The following is a description of a gene set: Genes having at least one occurrence of the motif TGACCTTTGNCCY in the regions spanning 4 kb centered on their transcription starting sites. This matches the PPARA transcription factor binding site V$PPAR_DR1_Q2 (v7.4 TRANSFAC). species: Homo sapiens Human Gene Set: PPAR_DR1_Q2, and this is the list of marker genes: INSR, PHYHIP, DCTN1, PRDM16, SPACA6, CNOT9, ARL6IP1, ARHGEF7, TMEFF1, IGF2BP1, AQP7, PDZK1, COL16A1, HHEX, IFFO1, TP53, ATP2B1, CDK16, GDPD2, RNF128, HOXA3 (NCBI Gene Id 3200), NR2C1, ATN1, TPM2, LRFN4, MPC2, FNDC9, PRDM13, PAPLN, CREB3L3, CSNK2A1, CLRN3, CCDC14 (coiled-coil domain containing 14), SRSF6, TPCN1, NET1, ROCK2, SZT2, SPRY4, CELF3, SRSF4, BCKDHB, SATB1, BOK, ZBTB12, TGIF1, FGF9, SCNM1, BABAM2, CLDN15, SSH2, SLC25A1, HDAC4, ZIC4, RASAL1, C14orf132, DCTN2, ACOT8, CDX1, MSRB1, RBBP6, EIF4G1, WRAP53, BIN3, NR1H3, LAMP2, SMG5, AP1B1, ZNF385A, SHFL, NFE2L2, MAP3K11, RPL27, TEF, ESRRA, EEF1B2, NR2F2, IL4, GRPEL1, ARRDC1-AS1, GPD1, PNPLA2, GOLGA4, PTH1R, DNMT3A, GAPDH, SLC25A13, TTYH1, PATZ1, BHLHE41, TBX6, MARK2, NEUROG2, RTN4, ZNF597 (zinc finger protein 597), CUTA, KIF6, MLST8, PAX6, SS18, POU5F1, SMYD5, MTTP, TRPC5, NCDN, RBP2, CSRNP3, RBKS, HOXD3, SLC39A5, MREG, LRP1, GABARAPL2, SNRPF, NUDT22, OTUD7B, MED8, TMEM79, MASP2, PHB2, C1orf116, IQCD, ZBTB40, TNFRSF12A, EFEMP1, GRM3, ALPI, MRPL11, MAP2K3, CHST8, HNF1A, AGPS (alkylglycerone phosphate synthase), LPL, CSF2, RCL1, ACOT7, NDUFS1, PRR7, HIBADH (NCBI Gene Id 221893), PAX7, ADAMTS19, SMTN, SLC34A3, FABP1, SPEF1, SLTM (SAFB like transcription modulator), EMG1, LYSMD1, MIR22HG, PAN2, TOM1L2, ERBB2, NR1D1, MARCKSL1, MICAL2, WBP2NL, TMEM120A, ZNF485, NHERF4, LRFN5, YPEL3, WDPCP, FAM170A, TMEM43, WDR81, RTKN, ANGPTL8, MMD, UBE2R2, PRODH2, CKMT1B, EFNB3, UBE2K, HOXB6, SAMD14, A1CF, INHBC, F12, RRBP1 (ribosome binding protein 1), PAK1IP1, PPARGC1A, USP12, DRC3, CELF1, ENO3, GLTP, CXCL14, CRABP2, MYH10, RBMS1, PCDH7, ILRUN, NPSR1-AS1, MRPL1, NEDD9, PRKAG1, OVOL1, NR4A3, AOC2, RPRD1B, UQCR10, STOML2, PLEC, SELENOI, C3orf18, FMNL1, THPO, KCNE5, PRDM1, KLK6, SLC25A5, SEC24C, ARFGEF2, NR2F6, PPTC7, PGF, STAT5A, HOXB3, GBF1, MLLT6, USP37, SYNPO2L, OBSCN, TOMM70, TRPT1, GABRG2, PCBP4, CDX2, ZSWIM3, ASXL1, HTN1, HMGCS2, GCH1, ROR1, SLC23A3, CLCN5, COL15A1, MOV10, TTI1, NRAP, ATAT1, HSD17B8, DNAJA2, BLTP3A, PAK4, PRRX2, SHF, PLIN1, RCE1, NR2F1, RTP3, GBX2, ACADVL, REST, SLC7A9, SLC25A34, PLPPR1, ZFHX3, ARID4A, ARHGAP21, CHCHD4, PFN1, DLG4, TAF2